The following is a description of a gene set: Catalysis of the reaction: GDP + H2O = GMP + phosphate. Mouse Gene Set: GOMF_GDP_PHOSPHATASE_ACTIVITY species: Mus musculus, and this is the list of marker genes: Entpd3, Entpd8, Gbp2, Entpd2, Entpd7, Entpd4, Entpd5, Entpd6, Entpd4b, Cant1, Gbp2b, Entpd1